The following is a description of a gene set: species: Mus musculus Mouse Gene Set: chr10B3, and this is the list of marker genes: Gm46224, 4933411G06Rik, Gm24256, Pln, 4930594A02Rik, Gm18120, Man1a, Gm31849, Gm3473, Gm36065, Slc35f1, Nus1, Gm5040, Msl3l2, Gm6991, Gm40646, Cep85l, Nepn, Gm26180, Ros1, Sim1, Asf1a, Ascc3 (activating signal cointegrator 1 complex subunit 3), Gm20597, Gm23906, Gm47612, Gm6627, Gm26257, Tmem229b-ps, Mcm9, Gm46189, Gm46190, Gm40645, Zfa-ps, 1700042O05Rik, Gm20630, Gprc6a, Gm29794, Rfx6, Gm25602, Gm46199, Gm40650, Lilrb4b, Gm17823, Dcbld1, Gm16998, 4930466K18Rik, Grik2, Gm46223, Gm40649, Fam162b, Fam184a, Rps19-ps10, Gm18513, Gopc, Lilrb4a, Vgll2, Gm36229